Given this list of marker genes SPATA2, HOMER1, KSR1, GNB4, HAX1, MMS19, AIM2, GRAPL (NCBI Gene Id 400581), MAP2K1, GNB1, GAB2, HCLS1, TRAT1, LAT, CARD9, TRAF3, TICAM2, STING1, NOS1AP, RIPK1, ARF6, BLNK, PIK3R1, TRAF2, NLRP3, CARD10, GAB3, SPAG9, ROPN1B, SH2B1, BANK1, MYD88, LAMP2, SOCS6, SH3RF1, PTPN11, CRKL, AKAP13, SH2B2, DDX3X, IRS2 (NCBI Gene Id 90066), AXIN1, DAB2IP, IRS1, SHANK1, SHB, RIPK2, GNB2, DOK2, RACK1, DUSP19, FRS2, DOK7, WWC1, DAB1, SHANK3, IRAK2, IQGAP1 (IQ motif containing GTPase activating protein 1), IFNAR1 (interferon alpha and beta receptor subunit 1), LRRK2, CDH5, CD3E, WDR59, PAG1, CD3G, KHDRBS1, DEDD2 (NCBI Gene Id 162989), SCRIB, WWC2, TICAM1, CAPRIN1, YWHAE, TRADD, NCK2, WWC3, MAVS, GRIP1, BCL10, STAP1, SLA2, BEX1, RGS14, GAB4, CDC42SE2, ABI3, TRAF5, MAPK8IP2, NLRP6, FCRL2, SARM1, FMR1 (NCBI Gene Id 5421), NUP62, ABI2, ABI1, TAX1BP1, SH2B3, HOMER2 (NCBI Gene Id 9455), IFNAR2, TRAF4, GNB5 (NCBI Gene Id 82962), TIRAP, MAPK8IP1, SHANK2, GNB3, MAGI2, SOCS7, ZDHHC11, IKBKG, G3BP2, FRS3, NLRP1 (NCBI Gene Id 82286), TRAF6, MAP2K2, KSR2, SOCS2, GRB2, NCK1, FADD, MAPK8IP3, STAT3, MPP7, GRB10, STAP2 (NCBI Gene Id 55620), DLG5, SORBS1, SHC1, TRAF1, CRK, LDLRAP1, IRAK1BP1, GAB1, here is a description of the gene set: Human Gene Set: GOMF_SIGNALING_ADAPTOR_ACTIVITY The binding activity of a molecule that brings together two or more molecules in a signaling pathway, permitting those molecules to function in a coordinated way. Adaptor molecules themselves do not have catalytic activity. species: Homo sapiens